The following is a description of a gene set: Human Gene Set: BYSTRYKH_HEMATOPOIESIS_STEM_CELL_QTL_TRANS studied in species Mus musculus Transcripts in hematopoietic stem cells (HSC) which are trans-regulated (i.e., modulated by a QTL (quantitative trait locus) not in a close proximity to the gene). We combined large-scale mRNA expression analysis and gene mapping to identify genes and loci that control hematopoietic stem cell (HSC) function. We measured mRNA expression levels in purified HSCs isolated from a panel of densely genotyped recombinant inbred mouse strains. We mapped quantitative trait loci (QTLs) associated with variation in expression of thousands of transcripts. By comparing the physical transcript position with the location of the controlling QTL, we identified polymorphic cis-acting stem cell genes. We also identified multiple trans-acting control loci that modify expression of large numbers of genes. These groups of coregulated transcripts identify pathways that specify variation in stem cells. We illustrate this concept with the identification of candidate genes involved with HSC turnover. We compared expression QTLs in HSCs and brain from the same mice and identified both shared and tissue-specific QTLs. Our data are accessible through WebQTL, a web-based interface that allows custom genetic linkage analysis and identification of coregulated transcripts. from publication Bystrykh L, Weersing E, Dontje B, Sutton S, Pletcher MT, Wiltshire T, Su AI, Vellenga E, Wang J, Manly KF, Lu L, Chesler EJ, Alberts R, Jansen RC, Williams RW, Cooke MP, de Haan G (PMID 15711547), and this is the list of marker genes: PEX14, GRIN2D, MYBL1, ABCB8, DLG3, CSNK1E, STK25, TRIM21, SLFN12, MBP, REXO1, ZNF703, EXTL3, KRT2, NR2F1, HNRNPUL2, TSPYL1, TSPAN6, MACROD2, CBX5 (chromobox 5, NCBI Gene Id 23468), LMNA, NPNT, TRBC1, HINFP, CELA2A, SEC23IP, KRT4, FNTA, GNA13, NR2C2AP, DDAH2, EBF3, FDFT1, ADPRS, GRIK1, WDR43, RPA2, RNASE2, ACRBP, SCN8A, ZDHHC5, ANG, TRBV13, MAPK7, DNAJC7, HDGF, NDUFV1, MYO1F, AK2, DDX52, ZIK1, KLC1, FADS1, HCCS, ARF3, MED24, MMP17, VTN, PRRG2, MBD2, ITIH3, CHIA, CCNI, IFNAR2, YAP1 (Yes1 associated transcriptional regulator), PDXDC1 (NCBI Gene Id 23042), WDR46, MINDY1, TOMM70, OTP, CRY2 (NCBI Gene Id 1408), TM2D2, ATP6V1H, GZMA, SART3, FASTK, AMOTL2, PLXNA2, TMPRSS2, BCL7B, SRSF10, FOXRED1, SMNDC1, C5AR1, DDA1, MSR1 (macrophage scavenger receptor 1), MRPL12, PIK3C2G, SNAPIN, TTR, PTK6, ARL6IP4, XPNPEP1, MYNN, KCNQ2, CDH6, VEGFC, ALDH1A2, COX8C, IGKV4-1, TOMM5 (translocase of outer mitochondrial membrane 5), RBPJ, HR, HOXB6, TUT7, SRRM1, IL18BP, RPS6KB1, CFH, MCM3AP, ENPEP (glutamyl aminopeptidase), NEU1, SKAP2 (src kinase associated phosphoprotein 2), G3BP1, DCUN1D5, CD79A, GAS8, VPS26B, RAB4B, GAST, KCND2, SDHAF1, CYP1A2, PPP6C, TSPAN12, AKAP17A, PCBP2, USP19, USP39, ACKR3, EIF2AK3 (NCBI Gene Id 9451), MYO6, GIPC2, PBX1, MRPL16, RBPMS, TBC1D15, FHOD3, SMIM20, PDE4DIP, ATF2, IFT25, IL13, ARHGEF28, XRCC6, TMEM129, GRIN2C, STAR, ALK, RALA, PIK3CD, TEC, GNAS, LGALS4, SMPD1, VEGFB, DDX56, CYB5R1, CYP4F8, RASA4B, FUS, APBB1IP, TYRP1, OTULINL, CTNNBIP1, DCPS, LUC7L, TWSG1, LPGAT1, ADSS2, ID2, EIF2S2, PIP5K1B, IFT20, POLR2C, AKR1C4, TNFRSF8, CYP2B6 (cytochrome P450 family 2 subfamily B member 6), HSD3B2, GUCY2C, SYK, CDX4, IFT27, GLB1, CRYGD, IL18R1, ASCL1, COX7A2L, CUL2, DHX9, GABPB1, YWHAG, NAXE, PTGFRN, PIK3R1, CD68, PSAP, MRPL28, SYNGR1, GTF3A, ALKBH5, HOXA1, WBP2, WIPF1, NMT2, SOX15, NEDD4L, NAGK, NEFM, SEC14L2, ALAS1, CD5, CYTH2, ZNF644, CUX2, GSTK1, IGLV1-50, PCSK5, MEOX1, KCNA4, ZC3H15, CA3, PTPRA, HCN2, PAFAH1B2, ST7, COL26A1, NEFL, CST9L, MFSD14A, NUCKS1, ECHS1, SLC5A6, HNRNPR, CLK4, CP, FYTTD1, RTKN, ZFP36L1, CCL27, CHD1, SOCS1, FEM1A, IYD, TLK2 (NCBI Gene Id 11011), PRRX2, TIMM8B, MAGOH, TCIRG1, STXBP2, CCL3, RAG1, H2AC18, PLXND1, ELOVL2, EDN1, STK38, RRP1, TCF3, BMPR1A, NOG (NCBI Gene Id 9241), QSOX1, ITGAV, ADCY6, TERF2, TPK1, COPA, ZNF688, HCFC1, CRIPT, CDO1, FCGR1A, PSMD9, VCL, SLC16A7, ACOX1, ACP6, SP4, NBEAL2, NMI, PLCB1, SETD1A, AKTIP, PSMD1, PWP1 (PWP1 homolog, endonuclein), YIPF4, FBLN1, UCP1, RHOD, LIMK1, LRRFIP2, ATP1A1, DUS1L, DNASE1, NOTCH4, PDE6A, CDS2, SELENOF, AXIN1, ZDHHC6, CA5A, HAT1, SLC25A14 (NCBI Gene Id 9016), SYT3 (NCBI Gene Id 84258), THBD, SEMA6D, CNTNAP1, CAPN2, INHA, BTG1, HOXB4, CEBPG, HAS1, RNF14, KLRK1, CDX2, LIG3, COLQ, KCTD9, GAR1, WBP1L, MAU2, CCL2, MTMR14, UROS, SMG1, POLR2I, MRPL48, ADGRL1, DNTT, NDFIP2 (Nedd4 family interacting protein 2), TULP3, IL1RL1, EDN3, CYP2C19, DNAJB2, XCL1, ITGA6, AURKA, RAB11B, MIA, ZNRF2, RGS11 (regulator of G protein signaling 11), ZNF746, ZRANB2, ESRRA, SFT2D1, NFIX, IGFBPL1, HAUS3, HTRA1, SCN1B, PHF13, CHD1L, IER3, DGKA, BTF3, C4orf3, CACNA1S, ATP6V1B2, NPAS1, REEP1, PDCL3, GNGT2, IRX3, SERPINF2, KRTAP5-4, IL13RA2, HAND2, TWIST1, PLRG1, IBSP, TNFAIP8L1, XPO7, SLC35G6, TIMM10B, SLC12A4, ZNF518B, FGF18, COQ4, CTNND1, MED22, NR0B1, RAD17, IGKV5-2, SCT, MAPKAPK5, SKIC2, CD48, BOK, CSNK1D, OGDH, GJA5, LMO1, OCA2, NLK, HRH1, SIRT3, MYO5A, UBE2V2, ATP6V1D, COASY, ERO1A, CD40, STK24, PDXK, NFYC, SWAP70, DNMT3A, FXYD3, GDPD3, TPP1, STX4, EIF3B (NCBI Gene Id 8662), RECQL, SF3B6, ZNF226, LBP, MAP3K1, NAA15, PHLDB1, VAPA, SGCD, TRPM1, KIFC3, PRB1, COX6B2, MRPL54, ZNF277, DESI1, KIAA0930, SERPING1, NFKB1 (NCBI Gene Id 4790), VPS37C, CAPN7, KLK1, PREB, TRIM43, RAB23, FKBP9, SERPIND1, ENC1, H19, ITSN1, CAVIN3, LEF1, NUSAP1, TIE1, CACNA1G, SRI, NAALAD2, SNAP23, SETD4, CUEDC1, WNT7A, HTT, FRYL, LEP, SNCB, SLC30A9, PARK7, TFCP2L1, WIPI2, PIPOX, JOSD2 (NCBI Gene Id 126119), NR5A2, BID, NACC2, UBA5, MKRN1, DDR1, PAK3, TECTA, RAN, NPEPPS, NPDC1, POLR2G, ALDH1A1, CERS2 (ceramide synthase 2), BROX, STX6, SEBOX (SEBOX homeobox), RPL39L, SEPSECS, ADSL, GPC4, TMEM199, BTBD17, TPO, IL1RN, CHRNG, ANKRD46, RAP2B (RAP2B, member of RAS oncogene family), ZDHHC9, H2AC21, BRD4, STAT6, ZNF436, GYS1, GLB1L (NCBI Gene Id 79411), ZKSCAN3, ABCF1, CDH3, ATP6V1E1, CRADD, VAV1, CSF3, REN, ZNF276, EML5, SLC25A19, NR1D2, MAB21L2, IFITM3 (interferon induced transmembrane protein 3), GYG1, GPR33, RFC5, RGS19, PDCD1, STX3, ZNF708, RBM18, COL4A4, IPO8, ADAM10, IRF2BP1, PMS2, GOSR2, CDC20, PDE1A, FKBPL, ICAM2, SYNJ2BP, CD34, PPIL2, NFKBIE, SMAD1, MNAT1, EFHD1, IRF8, FZD3, HIPK2, RAB11A, ROCK1, CHMP6 (NCBI Gene Id 79643), IGFBP2, UBE2I, FGGY, HNRNPD, BLZF1, SCHIP1, CD74, PTTG1, POLR1C, GHRHR, CTDSP2, NDUFAF1, INPP5A, IGFBP5, GSTM5, GALR3, HSPD1, CDK8, TEK, WBP1, MUC17, IGHV3-72, KIAA0319L (NCBI Gene Id 79932), NPPA, AGFG1, AHCY, ADARB1, USP9X, KIAA1217, PCYT1A, NSDHL, GLTP, ETF1, MPP1 (MAGUK p55 scaffold protein 1), POU5F1, UGCG, RPS23, ARID1A, ADIPOQ, PCGF2, HAND1, TRAF6, IL2RB, GAB2, RPP25L, CRB3, FGFR1, ONECUT1, SLC1A5, MPEG1, ANKRD2, COMT, HOXD1, PSMD11, UBE2T, HTR2B, TUBA1A, MOBP, GBF1, RRN3, B3GALNT1, ARPP19, FBXW2, GSTT2 (NCBI Gene Id 91334), STAU1, TNS2, CCNA1, DVL2, CCL4, ARIH2, EIF5B, ITGB3, SUB1, MBD3, MRPS34, TBXAS1, DYNC1H1, OMD, HLA-DMB, PSMB7, NDUFC1, SIRPA, HNRNPH2, PROC, IL12B, FANCM, GRIA1, TRAV38-2DV8, SNX12 (sorting nexin 12), TGOLN2, CYCTP, BPIFA2, ANPEP, IL6ST, TFRC, HOXB13, KDELR1, CASP9, IKBKB, LY6H, RORA, SLC25A44, PMM2, PRR13, BMI1, AKR1B10, CD320, PACRGL, TRBV30, KCNJ1, GIPC1, SEPTIN2, GFRA1, LIPE, BRAF, TNFSF12, H2AZ1, NAP1L1, PDRG1, HSD3B1, SELENOK, RHOH, IMPA2, GSK3A, PTPRN, CSRP1, COL4A1, ALDH3A2 (NCBI Gene Id 224), MEA1, TNNT3, TMEM191C, UBE2Z, HOXA2, GLO1, HNRNPA1L2, CDCA7L, SLC27A1, TSPO2, RGL2 (ral guanine nucleotide dissociation stimulator like 2), NDUFV2, VCAM1, MLLT1, SOX2, PPP1R17, TCF4 (NCBI Gene Id 6925), RWDD1, INSL3, RNF103, CBFB, STOM, H1-2, NIP7, BRD2, ABCB10, PGR, SNRNP40, H1-6, PROM1, COL17A1, ECI1, MAP3K2 (mitogen-activated protein kinase kinase kinase 2), MATR3, DICER1, PTPN23, NCAM1, WNT8A, HMGB1, CRKL, ENG, MTOR, SETDB1, NKIRAS1, PLXNB2, RGS16, ZNF398, KLF9, PRKAR1A, CEACAM1 (NCBI Gene Id 634), CXCL10, UBTF (NCBI Gene Id 7343), RAD54L, NONO, MAF, CCDC6, UBLCP1, ZMYND8, CHRNA6, MAPK12, SNX10, ADIPOR1, PLA2G2C, B3GAT3, TH, MUC5AC, OSBPL5, PNCK, MRPL13, MDM1, TOR3A (torsin family 3 member A), ETV2, IMPDH1, SEC16A, CDKN3, CBL, TGFB3, UHMK1, TNFSF11, IGHV1-2, ESR1, MFHAS1, HTR1B, STAT3, GOLT1B, KIF5C (NCBI Gene Id 7860), NPR3, FOXG1, AXIN2, SLC4A4, CNOT8, ANKRD17, KLK8, VLDLR (very low density lipoprotein receptor), TFAP2A, MAN2A1, ACVRL1, SORBS3, RAD52, DLX3, CD14, FIGNL1, NR2F6, GSPT1, GPX1, GPSM1, SYCE2, PEX5, ART2BP, SERPINA3 (serpin family A member 3)